Given this list of marker genes PSMA5, SEPTIN11, RAVER2, GRM5, CYBRD1, KLLN, PPM1E, KIRREL3 (kirre like nephrin family adhesion molecule 3), GJA5 (gap junction protein alpha 5), SOCS5, CCDC73, ALKBH5, ARSL, NHLH1, DDX5, TAF9B, WASL, OSCAR, AMMECR1, ANXA7, GABRB3, FAM222B, here is a description of the gene set: Genes predicted to be targets of miRBase v22 microRNA hsa-miR-4732-5p in miRDB v6.0 with MirTarget v4 prediction scores > 80 (high confidence targets). Human Gene Set: MIR4732_5P from publication Chen Y, Wang X (PMID 31504780) species: Homo sapiens